The following is a description of a gene set: The chemical reactions and pathways involving quinone. Human Gene Set: GOBP_QUINONE_METABOLIC_PROCESS studied in species Homo sapiens, and this is the list of marker genes: ADCK2, COQ6, AIFM2, RTN4IP1, PDSS2, COQ4, PDSS1, COQ9, CRYZL1, COQ8A, NQO2, COQ5, COQ8B, PPTC7, COQ3, ADH4, FDX2, STARD7, NDUFA9, UBIAD1 (NCBI Gene Id 7801), NQO1, COQ2, COQ7, FDXR